The following is a description of a gene set: Human Gene Set: GOBP_PYRIMIDINE_NUCLEOSIDE_MONOPHOSPHATE_CATABOLIC_PROCESS The chemical reactions and pathways resulting in the breakdown of pyrimidine nucleoside monophosphate, a compound consisting of a pyrimidine base linked to a ribose or deoxyribose sugar esterified with phosphate on the sugar. studied in species Homo sapiens, and this is the list of marker genes: UPP2, NT5M, DPYD, DPYS, TYMP, UPB1, NT5C, UPP1